Given this list of marker genes IL12B, TGFBR2, FBN1, TGFB2, ADAMTS19, LYN, THBS2, FLNA, MYH11, ACTA2, EFEMP2, HLA-B, BRF1, GJA5, IPO8, B3GALT6, ZMPSTE24, MED12, NODAL, COL3A1, FMR1, THSD4, LMNA, ATP6V1A, FBLN5, GJA8, TGFBR1, BGN, SMAD3, MLX, LOX, here is a description of the gene set: species: Homo sapiens An abnormal localized widening (dilatation) of the tubular part of the ascending aorta. Human Gene Set: HP_ASCENDING_TUBULAR_AORTA_ANEURYSM Ascending tubular aorta aneurysm